The following is a description of a gene set: Mouse Gene Set: MIR_194_1_3P from publication Chen Y, Wang X (PMID 31504780) studied in species Mus musculus Genes predicted to be targets of miRBase v22 microRNA mmu_miR_194_1_3p in miRDB v6.0 with MirTarget v4 prediction scores > 80 (high confidence targets)., and this is the list of marker genes: Glce, Neto1, Cd200r3, Ypel5 (NCBI Gene Id 69687), Hspe1, Mylk, Fosl2, Tfap2a, Isoc1, Ercc6, Myo1e, Fads1, Capn5, Rnf150, N4bp2l2, Ppp1r3g, Stam, Plp1, Dusp1, Chrm3, Kras, Ugt8a, Nsd1, Canx (NCBI Gene Id 66219), Plekho2, Pacsin2, Casp2, Camta1, Zkscan8, Sh3pxd2a, Ube2d3 (NCBI Gene Id 99495), Ptgir, N6amt1, Pkd2, Selenoi, Mob1b, Msrb3, Pcgf6, Pdgfc, Tspan12, Pitpnm2, Lgals12, Plcxd3, Dmd, Pptc7, Il33, Ppfia1, Tmco1, Tox, Txndc9 (thioredoxin domain containing 9), Rpf2, Mtfr1l, Arc, Dgkd, Mtcl2, Cyb5a, Naf1, Nrn1, 2410004B18Rik, Plk2, Ccn4, Fbln2, 1700019A02Rik, Mprip, Mapk9, Lrrfip2, Kdm1b, Rcl1, Kpnb1, Ctnnd1, Slc7a5, Tor1aip1, Fam53b, Pdcl, Slc5a7 (solute carrier family 5 (choline transporter), member 7)